Given this list of marker genes Myt1l, Slbp, Efhc2, Dgkh, Mtmr4, Grk5, Cep350, Usp21, Tent5d, Rad18, Jmjd8, Zmym2, Epdr1, Ehhadh, Map3k20 (mitogen-activated protein kinase kinase kinase 20), Ythdf3, Fastkd3, Gabra2, Leng8, Syde2 (synapse defective 1, Rho GTPase, homolog 2 (C. elegans)), Adamts6, Dop1a, Vkorc1l1 (vitamin K epoxide reductase complex, subunit 1-like 1), Wdr82 (WD repeat domain containing 82), Sestd1, Chic1, Bicd2, Pde7a (NCBI Gene Id 99869), Mal2, Cgas (NCBI Gene Id 214763), Tia1, Epc2, Pdia5, B3galt1, Nkx2-2, Eml6, Ldb2, Dffb, Kctd12, Ccl7, Mmp11, B4galt5, Wdr20, Slc23a1, Nphp4, Rgmb, Zhx3, Pdcd4, Agfg1, Ajap1 (NCBI Gene Id 433810), Mboat2, Tfcp2l1, Dnajb14, Becn1, Prdm1, Zfp507, Nucks1, Fbxo8, Etnppl, Glra1, Ttc28, Atp5mc3, Btaf1, Inpp4a, Cebpg, Tma7, Ahcyl1, Myc, Shisa7, Atrnl1, Mtcl2, Arhgef18, Ppt1, Glul, Kcnh8, here is a description of the gene set: species: Mus musculus Mouse Gene Set: MIR_3082_3P from publication Chen Y, Wang X (PMID 31504780) Genes predicted to be targets of miRBase v22 microRNA mmu_miR_3082_3p in miRDB v6.0 with MirTarget v4 prediction scores > 80 (high confidence targets).